The following is a description of a gene set: Human Gene Set: HALLMARK_UV_RESPONSE_UP Genes up-regulated in response to ultraviolet (UV) radiation. from publication Liberzon A, Birger C, Thorvaldsdóttir H, Ghandi M, Mesirov JP, Tamayo P (PMID 26771021) species: Homo sapiens, and this is the list of marker genes: BMP2, PDAP1, NPTXR, KCNH2, ACAA1, RAB27A, MAOA, BCL2L11, TGFBRAP1, GCH1, CLTB, CYP1A1, NPTX2 (NCBI Gene Id 95714), RFC4, HSPA2, JUNB, PRKACA, PPAT, PPT1, ATP6V1F, C4BPB, BTG2, MARK2, IL6ST, ALAS1, DNAJB1, CHKA, FKBP4, AQP3, DNAJA1, PPIF, TYRO3, BSG, CXCL2, ALDOA, PPP1R2, SULT1A1, HMOX1, GGH, BAK1, EIF5, AGO2, NFKBIA, ATF3, RPN1, CA2, SIGMAR1, ONECUT1, BTG1 (NCBI Gene Id 694), RET, TARS1, RRAD, EPCAM, ABCB1, WIZ, ATP6V1C1, DLG4, PDLIM3, LHX2, FOSB, SLC6A12, HTR7, GAL, CDC34, IGFBP2, HYAL2, CREG1, DDX21, PSMC3, NTRK3, LYN, CTSV, RXRB, FEN1, NXF1, CDO1, FMO1, MGAT1, H2AX, RASGRP1, CLCN2, PRKCD, NAT1, NUP58, FGF18, GLS, IL6, MRPL23, TCHH, DGAT1, TACR3, E2F5, CYB5B, MSX1, YKT6, GRINA, TMBIM6, SLC6A8, SOD2, HSPA13, BID, CCK, CCND3, CDC5L (NCBI Gene Id 988), MAPK8IP2 (NCBI Gene Id 51748), TUBA4A, SQSTM1 (sequestosome 1), FOS (Fos proto-oncogene, AP-1 transcription factor subunit), UROD, AP2S1, FURIN, PRPF3, STK25, PARP2, AMD1 (adenosylmethionine decarboxylase 1), CHRNA5, KLHDC3, CCNE1, CASP3, APOM, ICAM1, SPR, ENO2, HNRNPU, IRF1, TFRC, HLA-F, SELENOW, PLCL1, MMP14, COL2A1, ASNS, CDK2, EPHX1, CDKN2B, GPX3, POLE3, OLFM1, CEBPG, SLC25A4, TAP1, TST, POLG2, SHOX2, PTPRD, ARRB2, BTG3, STIP1, CDKN1C, RHOB, POLR2H, EIF2S3, NKX2-5, GRPEL1, STARD3, NR4A1 (nuclear receptor subfamily 4 group A member 1), CNP, CYB5R1